The following is a description of a gene set: Human Gene Set: HP_ABNORMAL_CAUDATE_NUCLEUS_MORPHOLOGY Abnormal caudate nucleus morphology studied in species Homo sapiens Any structural abnormality of the caudate nucleus., and this is the list of marker genes: COASY, LONP1, FTL, VPS13A, MT-ATP6 (NCBI Gene Id 4508), ADAR (NCBI Gene Id 3427), FOXP2, TUBB3, HTT, ATP13A2, TUBB2B, OPHN1, BSCL2, ASNS, TIMM8A, DCX, NUP62, NDUFAF5, TYROBP, TREM2, NUP54, NEK1, GCDH, SLC2A3, JPH3